Given this list of marker genes ADM, BCL2, SGCB, HES1, PROX1, LMOD2, ISL1, NRAP, HEY2, YY1, ADRA1A (adrenoceptor alpha 1A), MYOD1, MIR208A, CDK1, PGM5, P2RX2, TBX5, MEF2A, SORBS2, LMOD3, MIR199B, MIR24-1, ACTN3, NPPA, CTCF, PITX2, BMP4 (bone morphogenetic protein 4), LMNA, MYH3, TTN, KLHL40, TBX3, MYBPH, SMYD3, BVES, CACNA2D2, CHRNB1, RAMP2, CSRP1, MYOZ2, MYOM2, EDN1, KLHL41, WFIKKN1, CAV2, PI16, DNER, ACTA1, NEB, GSK3A, TNNT2, DCAF8, VEGFA, WNT10B, WDR1, OBSCN (NCBI Gene Id 84033), MEGF10, LDB3, PRKAR1A, EDNRA, TOMM70 (NCBI Gene Id 9868), MIR23A, MYOZ1, ANKRD1, LARGE1, SDC1, MYL9, HDAC9, TMOD1, TCAP, CAV3, NAGLU, UCHL1, SHOX2, ALPK3, PAK1, PPP3CB (protein phosphatase 3 catalytic subunit beta), RGS4, RYR1, BMP10, ITGB1, MYF5, MTOR, PLEC, ENG (endoglin), NFATC4, HNRNPU, MYORG, ATP2A2, MAML1 (NCBI Gene Id 9794), CFL2, PDGFRB, MYH6, BIN3, COL6A1, OBSL1, SIX4, KEL, ASB2, GATA4, FLNC, KRT19, ACTN2, SGCD, ACTN1, ZMPSTE24, SGCZ, ANK2, ATG5, LOX, ANHX, LMOD1, DMD, MYLK3, G6PD, NKX2-5, NOTCH1, CACNB4, FLII, SMO, PRKD1, SYPL2, SLC8A1, AKAP13, MEIS1, SYNPO2L, CCNB1, NACA, PPP3CA, RGS2, ACTN4, MYPN, TNNT3 (NCBI Gene Id 8044), MYBPC2, AFG3L2, FHOD3, CASQ1, MIR199A1, SMAD4, ADPRHL1, TPM1, PDLIM5, MYBPC1, NKX2-6, RCAN1, LRRC10, MYF6, AKAP6, NFATC2, MIR19A, PRICKLE1, MYBPC3, MIR195, HOMER1, MYO18B, TMEM182, CACNA1S (NCBI Gene Id 779), ANKRD23, PDGFRA, GPX1, PRKG1, FHL2, CNTNAP1, SRF, CAPN3, MYOM3, MIR1-1, TNNT1, SKI, PPARA, IGF1, XK, PARP2 (poly(ADP-ribose) polymerase 2), CXADR, NEBL, ACTC1, TMOD2, MYL2, CSRP2, CSRP3, BIN1, FOXP1, SELENON, ACTG1, PTCD2, SIX1, TBX18, KDM1A (NCBI Gene Id 23028), MIR19B1, MYH11, CFLAR, COL14A1, FBXO22, WFIKKN2, SPG11, EFEMP2, MYH10, TMOD4, STAC3, MYOG, BMPR1A (bone morphogenetic protein receptor type 1A), MYOM1, CTDP1, TMOD3, ALPK2, COMP, here is a description of the gene set: Human Gene Set: GOBP_MUSCLE_CELL_DEVELOPMENT The process whose specific outcome is the progression of a muscle cell over time, from its formation to the mature structure. Muscle cell development does not include the steps involved in committing an unspecified cell to the muscle cell fate. species: Homo sapiens